Given this list of marker genes CD300LF, IRAK1, BTK, TNIP1, TLR4, TLR9, IRAK4, MYD88, IKBKB, TRAF6, REG3G, MAP3K7, HSPD1, CCDC134, IRAK3, TIRAP, IRF1, IRAK2, CD300A, TLR6, IRF7, here is a description of the gene set: species: Homo sapiens A toll-like receptor signaling pathway in which the MyD88 adaptor molecule mediates transduction of the signal. Toll-like receptors directly bind pattern motifs from a variety of microbial sources to initiate an innate immune response. Human Gene Set: GOBP_MYD88_DEPENDENT_TOLL_LIKE_RECEPTOR_SIGNALING_PATHWAY